The following is a description of a gene set: species: Mus musculus Mouse Gene Set: GOBP_REGULATION_OF_HAIR_FOLLICLE_MATURATION Any process that modulates the frequency, rate or extent of hair follicle maturation., and this is the list of marker genes: Msx2, Fermt1, Gal, Wnt10b, Wnt5a, Cdh3, Ctnnb1, Gsdma3, Tgfb2